The following is a description of a gene set: Human Gene Set: GOCC_CUL4_RING_E3_UBIQUITIN_LIGASE_COMPLEX A ubiquitin ligase complex in which a cullin from the Cul4 family and a RING domain protein form the catalytic core; substrate specificity is conferred by an adaptor protein. species: Homo sapiens, and this is the list of marker genes: DCAF8L2, DCAF12, DDB1, DCAF5, DCAF13, DCAF8, DCAF10, ERCC8, DCAF11, DDB2, DCAF4L2, DCAF8L1, CUL4A, CUL4B, DET1, DCAF16, WDR77, FBXW5 (F-box and WD repeat domain containing 5), DCAF6, GLMN, DCAF7, DCAF17, DCAF4L1 (NCBI Gene Id 548643), AMBRA1, DCAF4, DTL, WDTC1, RBX1, CDKN1B, DDA1 (NCBI Gene Id 79016), CRBN, DCAF15, DCAF1, DCAF12L2, DCAF12L1, COP1, ARIH1 (NCBI Gene Id 25820), TRPC4AP